Given this list of marker genes EBP, ABCC9, CRIPT, UBE2A, KRT5, ABCB6, BLM, FERMT1, KRT14, here is a description of the gene set: Spotty hypopigmentation species: Homo sapiens Human Gene Set: HP_SPOTTY_HYPOPIGMENTATION